Given this list of marker genes Pitpnc1, Cad, Pds5b, Tmem68, Garre1, Nav1, Mindy4, Bace2, Usp49, Col4a6, Fmod, Fbn2 (NCBI Gene Id 407822), Nr1h2, Gpr183, Samhd1 (SAM domain and HD domain, 1), Ccnyl1, Actg1, Mtss1, Adat3, Wsb1, Bivm, Asb12, Nipsnap2, Zfp74, Fggy (NCBI Gene Id 75578), Dnase1l3, Itga8, Cfl2, Ppp3ca, Srrm2, Lnx1, BC048644, Rhd, Npsr1, Ptpn1 (NCBI Gene Id 19246), Kcnk4, Gatad2a, Fam169a, Tmem198, Akt3, Ppa1, Adck1, 2810004N23Rik, Mtfr1, Dock3, Tigd2, here is a description of the gene set: Genes predicted to be targets of miRBase v22 microRNA mmu_miR_7674_5p in miRDB v6.0 with MirTarget v4 prediction scores > 80 (high confidence targets). Mouse Gene Set: MIR_7674_5P species: Mus musculus from publication Chen Y, Wang X (PMID 31504780)